Given this list of marker genes GNAI1, GNAI3, ASAH1, RACGAP1, S1PR5, AKT2, S1PR3, MAPK1, MAPK7, SPHK2, PLCB1, MAPK12, SMPD2 (NCBI Gene Id 6610), MAPK6, PLCB2, AKT3, S1PR1, PLCB3, GNAI2, S1PR2, SPHK1, AKT1 (AKT serine/threonine kinase 1), PIK3C2B, MAPK3, MAPK4, here is a description of the gene set: studied in species Homo sapiens Human Gene Set: WP_S1P_RECEPTOR_SIGNAL_TRANSDUCTION S1P receptor signal transduction